The following is a description of a gene set: The directed movement of substances that are gaseous in normal living conditions into, out of or within a cell, or between cells, by means of some agent such as a transporter or pore. Human Gene Set: GOBP_GAS_TRANSPORT species: Homo sapiens, and this is the list of marker genes: RHAG, CA2, HBE1, HBA1, CYGB, IPCEF1, RHBG, HBG2, NGB, RHCG, HBD, AQP1, AQP6, HBG1 (NCBI Gene Id 8047), HBM, HBA2, HBZ, BPGM, AQP5, MB, HBB, HBQ1